Given this list of marker genes EDEM3, F7, TSHR (thyroid stimulating hormone receptor), EDEM2, NPPC, TIFAB, MAN1A1, SLC5A5, here is a description of the gene set: Any process that results in a change in state or activity of a cell or an organism (in terms of movement, secretion, enzyme production, gene expression, etc.) as a result of a glycoprotein stimulus. Human Gene Set: GOBP_RESPONSE_TO_GLYCOPROTEIN studied in species Homo sapiens